Given this list of marker genes LTK (NCBI Gene Id 4058), CAPN2, CAMK2A (calcium/calmodulin dependent protein kinase II alpha), BNIP3, MIR17, MIR320A, SMAD4, ADCY10, MIR195, ATP2A2, TIGAR (NCBI Gene Id 57199), CAMK2D, MAP3K5, MIR16-1, MIR34A, PTPN1, TP53, here is a description of the gene set: Any process that increases the rate or extent of striated muscle cell apoptotic process, a form of programmed cell death induced by external or internal signals that trigger the activity of proteolytic caspases whose actions dismantle a striated muscle cell and result in its death. Human Gene Set: GOBP_POSITIVE_REGULATION_OF_STRIATED_MUSCLE_CELL_APOPTOTIC_PROCESS species: Homo sapiens